Given this list of marker genes Pten, Braf, Prkar1a (NCBI Gene Id 80472), Prlr, Sptbn1, Men1 (multiple endocrine neoplasia 1), Thrb, here is a description of the gene set: Mouse genes annotated to increased thyroid carcinoma incidence (MP:0010346) retrieved from the Mouse Genome Informatics database via MouseMine from publication Motenko H, Neuhauser SB, O'Keefe M, Richardson JE (PMID 26092688) species: Mus musculus Mouse Gene Set: MP_INCREASED_THYROID_CARCINOMA_INCIDENCE